The following is a description of a gene set: As one of the most successful cancer therapeutic targets, estrogen receptor-alpha (ER/ESR1) has been extensively studied over the past few decades. Sequencing technological advances have enabled genome-wide analysis of ER action. However, comparison of individual studies is limited by different experimental designs, and few meta-analyses are available. Here, by ingesting large amount of E2-related transcriptomic data sets in breast cancer cell lines, we identified gene expression changes across 66 RNA-seq and 80 microarray experiments based upon the E2-induced fold change in gene expression. We derived the percentile of gene expression change for each individual gene normalized to all genes expression changes within each experiment, and filtered out genes that were detected in less than 80% of experiments. We derived consistency-to-inducibility maps consisting of genes across 146 comparisons. We identified 65 upregulated and 22 downregulated genes that were enriched in top 10% percentile of altered genes and consistent across at least 50% of comparisons as the meta estrogene up and down regulation signatures. Human Gene Set: LI_ESTROGENE_META_E2_RESPONSE_DN High confident estrogen down-regulated genes in breast cancer cells merged from 146 NGS datasets-based comparisons (10% topmost down-regulated genes and consistent in at least 50% comparisons). species: Homo sapiens from publication Li Z, Li T, Yates ME, Wu Y, Ferber A, Chen L, Brown DD, Carroll JS, Sikora MJ, Tseng GC, Oesterreich S, Lee AV (PMID 37272757), and this is the list of marker genes: BCAS1, FAM171B, BMF (NCBI Gene Id 90427), LIPH, STON1, PPFIBP2, DDIT4, BIK, LIMA1, BAMBI, RAB27B, CCNG2, BLNK, HCAR1, ENC1, SPRY1, VTCN1, EFNA1, GRHL3, TP53INP1, BTG2, IL1R1